Given this list of marker genes Tlr6, Tlr3, Map2k5, Adipoq (NCBI Gene Id 11450), Cactin, Nlrp10, Arrb1, Tnf, Park7, C5ar2, Lep, Tlr8, Afap1l2, Clec7a, Myd88 (myeloid differentiation primary response gene 88), Otud7b, Il1b, F2rl1, Il6, Il17d (interleukin 17D), Tlr2, Pycard, Wnt5a, Stat3, Syk, Elane, F2r, Bcl3, Rela (v-rel reticuloendotheliosis viral oncogene homolog A (avian)), Cd14, Ptger4 (NCBI Gene Id 19219), Ptprc, Fcna, Ddit3 (DNA-damage inducible transcript 3), Mavs, Lrrc19, Lamtor5, Bcl10, Ffar2, Apoa2, Gdf2, Chi3l1 (chitinase 3 like 1), Ripk1, Fadd, Prkd2, Mapkbp1, Camp, Bpi, Anxa4, Tlr4, Nod1, Ptpn22, F3, Zfp580, Hmgb1, Cd74, Serpine1, Nos2, Crp, Il18, Rigi, Cd2, Ssc5d, Klf4, Lbp, Il17f, Tlr7, Rab1a, Hyal2, Fcnb, Tlr5, Tlr9, Nod2, Anxa1, Tirap, Hspa1b, Tlr1, Cd244a, Prg3, here is a description of the gene set: Mouse Gene Set: GOBP_INTERLEUKIN_8_PRODUCTION species: Mus musculus The appearance of interleukin-8 due to biosynthesis or secretion following a cellular stimulus, resulting in an increase in its intracellular or extracellular levels.